Given this list of marker genes Gapdh-ps15, Nr1h2, Bex6, Dusp19, Qars1, Rida, Dbndd2, Tmem98, Sqstm1, Zgpat, Ntrk3, Hdac8, Dnaja3, Spry4, Ppm1e, Glg1, Efna1, Ifng, Prkrip1, Cryab, Cstdc4, Cyfip1, Wt1, Traf3ip1, Ptpn22, Agt, Prkca, Bex3, Wars1, Lsm14a, Pkia, Acp4, Caprin2, Zfp36, Cst3 (NCBI Gene Id 13010), Smad3, Clec16a (C-type lectin domain family 16, member A), Chordc1, Hfe, Bag5, Cactin, Serpinb9e, Limd1, Gprc5a, Heg1, Smyd3, Dcun1d3, Aqp11, Serpina5, Dnajc3, N4bp1, Rilp, Inca1, Cep85, Peli3, Ptprh, Xdh, Spink2, Sf3b3, Pten, Grin2a, Inhbb, Sfrp1, Rps7, Dbi, Fbln1, Hmg20b, U2af2, Mir26a-2, Smo, Ptprt, Mir125a, Ldc1, Mapk8ip1, Pinx1, Ins1, Impact, Ybx2, Vps28, Hspa4, Enc1, Garem1, Wwtr1, Cd300a, Pycard, Rgs2, Nell1, Wtip, Vtn (vitronectin), Patl1, Wac, Klhl40, Mir26a-1, Bex2 (brain expressed X-linked 2), Pfdn1, Senp2, Usp8, Socs3, Qki, Casp3, Acot8, Mir3960, Unk, Serpinb9c, Rtn1, Csnk2a2, Mtor, Wee2, Zfp598, Sgta, Shfl, Nqo1, Slc8a3, Dusp7, Rps23rg1, Flot2, Bdkrb1, Habp4, Zar1l, Ube2b, Ptpn3, Csta3, Pfdn5, Ntf3, Lats2, Nf2, Pebp1, Ago1, Cpeb4, Serpinb1b, Igfbp5, Epm2a, Eif4ebp2, Ddx3x, Samd4, Prkce, Spink12, Gadd45g, Map1a, Pparg, Insm1, Parp14 (NCBI Gene Id 72239), Mgat4d, Mirlet7b, Abl1, Npm1, Bax, Zar1, Trim21, Usp14, Spink6, Patl2, Ide, Mdm4, Dusp10, Fry, Edn1, Marchf7, Trib1, Fmr1, Eppin (epididymal peptidase inhibitor), G6pdx, Errfi1, Bex4 (brain expressed X-linked 4), Itgb1bp1, Nanos1, Spock1, Gzmc, Hspb1, Dap, Ednrb, Prkcd, Anks1, Ppp1r15b, Thbs1, Slit2, Nxn, Hsp90ab1, Parp16, Fscb (fibrous sheath CABYR binding protein), Lrp6, Socs4, Ireb2, Stfa2l1, Mgat3, Stfa2, Xrn1, Cast, Ggnbp2, Ctnnb1 (NCBI Gene Id 12387, catenin beta 1), Gapdh, Map3k20, Eif4enif1, Pabpn1l, Aatf, Snta1, Isg15, Mlxipl, Dmtn, Ptpn2, Paip2b, Eprs1, Nppa, Lats1, Hmgcr, Fxr1, Trim40, Plau, Nanos2, Eif3h, Serpinb8, Ntrk2, Bin1, Ctdsp2, Ceacam1, Deptor, Smpd1, Ago2, Tnrc6a, Ptprc, Ttc36, Cep78, Cdk5, Angpt1, Ccar2, Rb1, Gas1, Flcn, Crtap, Pibf1, Sfrp2, Gba1, Azin2, Cdkn2c, Eif4e2, Reck, Ppp1r15a, Psme3ip1, Xbp1, Rtn2, Apod, Cdkn2a, Azin1, Tardbp (TAR DNA binding protein), Ptk6, Mir26b, Mir1247, Ang (angiogenin, ribonuclease, RNase A family, 5), Gstp-ps, Ufsp2, Adipoq, Plk1, Fabp4, P3h1, Eif4a3l2, Stfa1, Hdac6, Fbxo5, Anxa2, Irf1, Snx12, Itgb3, Btg2, Mrpl13, Tmed2, Larp1, Pin1, Sfrp5, Tlk2, Cpeb2, Gzmb, Cstdc5 (NCBI Gene Id 100034684), Mdm2, Mif, Il1r2, Arrb2, Ncoa7, Mad2l2, Eif2ak4, Hdac2, Il1b, Inpp5e, Tia1, Men1, Prkch, Mad2l1, Nmnat2, Irak3, Rybp, Il2, Mir9-1, Serbp1, Ctsz, Wnt1, Rtraf (NCBI Gene Id 68045), Pip5kl1 (phosphatidylinositol-4-phosphate 5-kinase-like 1), Mtm1, Serpinb9h, Dedd, Cirbp, Ivns1abp, Pax6, Agap2, Bag2, Serpinb6e (NCBI Gene Id 435350), Phb1, Cdkn1b, Sesn2, Prmt6 (protein arginine N-methyltransferase 6), Rassf2, Usp9x, Mvp, Ager, Ptgis, Lin28a, Senp1, F8a, Smad7, Ppp5c, Cstdc3, Gipc1, Bag1, Usp7, Sirt7, Ncl, Cdh1, Prkag2, Gclc, Ddx6, Bdkrb2, Ppargc1a, Itgav, Cdyl, Gstp1, Usp19, Serpinb9, Psen1, Serpinb6b, Ilf3, Sh3gl2, Gstp3, Ubxn1, Parp10, Srp9, Lrrk1, Gpd1l, Serpinb10, Nck1, Samd4b (sterile alpha motif domain containing 4B), Park7, Insr, Tob1, Ifrd2, Igf2bp1, Mycbp2, Plec, Wnk4, Spopl, Rnf139, Socs1, Nnt, Eif2s1, Nolc1, Oga, Otud6b, Cst7, Nlrp12, Eif4e, Laptm4b, Per2, Gapdhrt (glyceraldehyde-3-phosphate dehydrogenase, retrotransposed), Dusp1, Srcin1, Lyn, Fetub, Cdk5rap3, Nos2, Ddrgk1, Tsc1, Gnaq, Mir1a-1 (NCBI Gene Id 387138), Flna, Thy1, Egfr, Cpeb3, Pfdn4, Dusp6, Cdkn1c, Bex1, Pdcd4, Paqr3, Rgs14, Minar1, Gsk3b, Prkcz, Dab2ip (NCBI Gene Id 98996), Tpr, Spred1, Tfap4, Hhatl (hedgehog acyltransferase-like), Hspa1b, Usp44, Hyal2, Prmt3, Tesk1, Tsc2, Tsg101, Sco1, Dtx3l, Atraid, Prkn, Bace2, Lilrb4b, Gapdhrt2, Smarcc1, Hnf1a, Rbm24, Wfdc6a, Fxyd1, Serpinb9g, Dnajc10, Styx-ps (NCBI Gene Id 100040244), Axin1, Cnot9, Stfa3, Pdcl3, Ptpro, Uchl1, Fbxo43, Ybx1, Jak3, Cnot10, Ric1, Ago3, Sirt3, Ppm1f, Sox4, Cdkn1a, Rtn4, Dusp22, Rela, Adgrb1, Rps3, Itm2b, Eif4ebp3, Serpinb9b, Capn3, Prr5l, G6pd2, Fem1a, Pfdn2, Pard6a, Grb7, Vps35, Slfn1, Kng2, Hspg2, Snx3, Spock3, Serpinb13, Coro1c (coronin, actin binding protein 1C), Cnksr3, Cep63, Hhex, Serpinb6c, Hnf4a, Prkaa2, Hint2, Rpl13a, Usp4, Cav1, Zfyve28, Tgfb1, Gabarapl2, Dapk3, Macroh2a1, Ang5, Trib3, Usp38, Ppp2r5d, Prkar1a, Limk1, Rpl5, Terf2ip, Nf1, Spred2, Qrich2, Serpinb6d, Ins2, Eif2a, Sufu, Wfikkn1 (NCBI Gene Id 215001), Rock1, Eif4ebp1, Abca7, Ubash3b, Gtpbp4, Cep43, Rybp-ps, Cav3, Pias3, Rab23, Spry2, Jun, Eif4a3l1 (NCBI Gene Id 671719), Chac1, Prkaa1, Mir143, Prpf18, Nanos3, Tspo, Akt1s1, Eif6, Serpinf2, Furin, Inpp5k, Atg14, Cd84, Drd2, Sh2d1b1, Mapt, Bc1, Timp3, Lamp3, Shb, Hgf, Adar (NCBI Gene Id 99861), C9orf72, Ccnb1, Sirt2, Klf15, Sumf2, Caml, Pkig, Cblc, Mir448, Cdk5rap1, Tnfaip3, Gadd45b, Bag6, Pml, Pkn1, Kirrel2, Cstdc6, Prg3, Slc2a10, Oxr1, Stk38, Pin1rt1, Ctla2a, Phf20l1, Mvk, Cadm1, Slc8a1, Cnot1, Ppef2, Wnk1, Svbp, Dapl1, Sh3bp5, Rpl23, Mirlet7g, Pik3r1, Timp2, Ctdspl, Dvl1, Dapk1 (NCBI Gene Id 76556), Eif2ak2, Cpeb1, Cib1, Spink5, Timp4, Pard3, Rasd2, Fhit, Cops9 (COP9 signalosome subunit 9), Rpl11, Mas1, Tm4sf20, Nr2f2, Lrrk2, Mir7116, Eif2ak3, Clu, Ajuba, Mir186, Itm2c, Nr1h3, Trim44 (NCBI Gene Id 80985), Serpine1, Svip, Psmf1, Bank1, Pid1, Serpinb6a, Kirrel1, Ago4, Tmem132a, Trim27, Chmp6, Trim71, Csta1, Ophn1, Serpinb1c, Pecam1, Tbc1d24, Cyp51, Gbp4, Rabgef1, Csta2, Fkbp8, Itm2a, Niban1, Taf9, Cstb, Rgn, Sh3rf2, Csnk2b, Inpp5f, Alad, Cadm4, Ctsa, Ibtk, Grk2, Zc3h12a, Mir135a-1, Ptx3, Gnl3l, Gzmn, Trim39, Taf7, Cpb2, Rara, Crb2, Rasip1, Dnajb2, Eif4a3, Gskip, Prkdc, Blvra, Styx, Epha4, Eif4g1, Pcif1, Ptpn6, Grin2c, Ldlr, Dusp3, Kng1 (kininogen 1), Pirb, Pbk, Shh, Dysf, Mllt1, Dtnbp1, Akt1, Tmed10, Socs5, Klhl31, Prkcg, Myocd, Dgkq, Nrg1, Sirt1, Rgp1, Smad4, Spink1, Apoe, Shmt1, Tnrc6b, Kat2b, Snca, Sorl1, Cd109, D1Pas1, Gadd45a, Hmg20a, Adarb1, Hap1, Bak1, Rack1, Igfbp3, Apc, Vbp1, Calr (NCBI Gene Id 12317), Psen2, Atg5, Ctdsp1, Eif2ak1, Gigyf2, Gps2, Ocln, Plpp3, Rtn3, Mir875, Hexim2, Ogt, Pkib, Spry1, Serpinb1a, Cln3, Zfp418, Plaa, Usp17le, Hipk2, Lrig2, Mir7b, Ecm1, Sirt4, Trp53, Tppp, Nop53, Dkk1, Lilrb4a, Serpinb9d, Fbxo7, Il10, Gga3, Ppia, Crkl, Trem2, Igf1, Ern1, Arrb1, Syncrip, Ptpn13, Myadm, Spon1, Inpp5j, Apcs, Dnaja1, Met, Suz12, Dhx36, Il18, Ppp4c, Hipk3, Caprin1 (NCBI Gene Id 99144), Ptprb, Bmp2, Spag9, Enpp1, Igf2bp2, Gfra2, Usp26, Plat, Ubxn2a, Paip2, Alkbh3, Malsu1, Tyms, Ptpn1, Timp1, Epha1, Usp5, Nup62, Hbegf, Cry1, Usp25, Wfs1 (NCBI Gene Id 22393), Ufl1, Scrib, Aida, Vps25, F2, Fyn, Prnp, Serpinb9f, Samsn1, Pus7, 2610042L04Rik, Fmn2, Rbm4, Gstp2, Pfdn6, Ptprj, Pura, Zbed3, Uchl5, Chp1, Serpine2, here is a description of the gene set: species: Mus musculus Any process that stops, prevents, or reduces the frequency, rate or extent of chemical reactions and pathways involving a protein. Mouse Gene Set: GOBP_NEGATIVE_REGULATION_OF_PROTEIN_METABOLIC_PROCESS